The following is a description of a gene set: species: Homo sapiens Human Gene Set: GOBP_REGULATION_OF_CELLULAR_EXTRAVASATION Any process that modulates the frequency, rate, or extent of cellular extravasation., and this is the list of marker genes: ITGA4, RIPK3, LYVE1, SELE, FUT4, IL1R1, CD99L2, MED23, CHST2, IL27RA, GCNT1, JAM3, ICAM1, MDK, FUT7, PLCB1, PDGFD, PLVAP, SELP, PTGER4, CCL21, CXCL12, BST1, MIR146A, AGER (advanced glycosylation end-product specific receptor), FUT9, CCL25, RIPOR2, CD47, CCR2, CHST4, ADAM8, ELANE, CCL28, ST3GAL4, FADD, CD99, XG, THY1, BCR